Given this list of marker genes Grin3b, Agap2, Bcl2l2, Grin1, Fyn, Gria2, here is a description of the gene set: studied in species Mus musculus Any process that results in a change in state or activity of a cell or an organism (in terms of movement, secretion, enzyme production, gene expression, etc.) as a result of a glycine stimulus. Mouse Gene Set: GOBP_RESPONSE_TO_GLYCINE